Given this list of marker genes HSBP1, IFIT2, IRF9, OAS2, LMO2, SERPINA1, IFI6, USP18, ANXA2, LY6E, MARCKS, CEBPB, MT1M, MX2, APOBEC3B, EIF4A1, IFIT3 (interferon induced protein with tetratricopeptide repeats 3), CREG1, IFI30, UBE2D3, IFI27, MX1, GLRX, PSMA6, LGALS3BP, TRIM21, FPR2, OAS1, VRK2, PLSCR1, TRIM22, IFIT5, IFI44, IFIT1, BLVRA, TAP1, HERC5, IFITM1, XAF1, PSMB9, ISG15, FCGR3A, TNFSF10, SERPING1, LAP3, CD74, PSME1, SP110, PSMA4, IFI44L, PYHIN1, IFITM2, PSME2, IL1RN, IFITM3, here is a description of the gene set: Genes up-regulated in peripheral blood mononuclear cell post-vaccination vs pre-vaccination in adults (18-40) after exposure to APSV Wetvax, time point anyD. Comment: Significantly Modulated Genes Common to Vaccinia and Yellow Fever Vaccination from publication Scherer CA, Magness CL, Steiger KV, Poitinger ND, Caputo CM, Miner DG, Winokur PL, Klinzman D, McKee J, Pilar C, Ward PA, Gillham MH, Haulman NJ, Stapleton JT, Iadonato SP (PMID 17651872) species: Homo sapiens Human Gene Set: SCHERER_PBMC_APSV_WETVAX_AGE_18_40YO_JOINT_TO_VACCINIA_AND_YELLOW_FEVER_UP Gene expression in human peripheral blood mononuclear cells was systematically evaluated following smallpox and yellow fever vaccination, and naturally occurring upper respiratory infection (URI). All three infections were characterized by the induction of many interferon stimulated genes, as well as enhanced expression of genes involved in proteolysis and antigen presentation. Vaccinia infection was also characterized by a distinct expression signature composed of up-regulation of monocyte response genes, with repression of genes expressed by B and T-cells. In contrast, the yellow fever host response was characterized by a suppression of ribosomal and translation factors, distinguishing this infection from vaccinia and URI. No significant URI-specific signature was observed, perhaps reflecting greater heterogeneity in the study population and etiological agents. Taken together, these data suggest that specific host gene expression signatures may be identified that distinguish one or a small number of virus agents.